Given this list of marker genes SMARCA2, PHF10, ACTL6A, DPF1, BCL11A, SMARCD3, SMARCC1, SMARCC2, ARID1B, ACTL6B, BCL11B, SMARCD2, DPF2, ACTB, SMARCA4 (NCBI Gene Id 6597), SMARCD1, ARID1A, DPF3, SS18L1 (NCBI Gene Id 26039), BCL7C, BCL7A, SMARCE1, BCL7B, SMARCB1, SS18, here is a description of the gene set: part of: SWI/SNF chromatin remodelers Studies in mice have identified two distinct BAF complexes that regulate neuronal differentiation, exemplifying the combinatorial control of BAF activity through changes to complex composition. Mature neurons that have exited the cell cycle, in contrast, contain a nBAF complex characterized by ACTL6B, the SS18 family member SS18L1 and DPF45 family members DPF1 and DPF3. studied in species Homo sapiens Reactome Pathway: Formation of neuronal progenitor and neuronal BAF (npBAF and nBAF)